Given this list of marker genes Tysnd1, here is a description of the gene set: This event has been computationally inferred from an event that has been demonstrated in another species.<p>The inference is based on the homology mapping from PANTHER. Briefly, reactions for which all involved PhysicalEntities (in input, output and catalyst) have a mapped orthologue/paralogue (for complexes at least 75% of components must have a mapping) are inferred to the other species. part of: Peroxisomal protein import species: Mus musculus Reactome Pathway: TYSND1 cleaves peroxisomal proteins electronically inferred by orthology from the curated human pathway